Given this list of marker genes Pim1, Pxdc1, Pdlim3, App, Nxn, Laptm4a, Mcl1, Vasn, Calm2, Tubb2a, Zfand5, Sbno2, Adgra3, Icam1, Pdlim7, Ccl7, Emc10, Stac2, Mmp2, Zfp36, Col9a2, Ski, Klc3, Mknk2, Pfdn5, Fosb, Selenom (NCBI Gene Id 216508), Tln1, Gadd45g, Msn, Socs1, Reep5, Ftl1, Zfp703, Tenm2, Clu, Slc6a6, Ptpn14, Bcl7c, Lamb3, Crem, Uap1, Use1, Ralgds, Plpp3, Jun, Pigp, Anp32a, Sertad1, Col6a1 (NCBI Gene Id 12833), Pink1, Rbpms, Gpx3, Map1b, Tmem59, Sgk1, Klf9, Ly6e, Ddah2, Ppp1r15a, Krt5, Rgs2 (regulator of G-protein signaling 2), Nfil3 (NCBI Gene Id 18030), Urah, Btg2, Gstm1, Nr4a1 (NCBI Gene Id 15370), Trim29, Eif3f, Dusp14, Zfp36l1, Il11ra1, Apoe, Rnf19b, Lmod1, Fgg, Gas1, Arid5b (AT-rich interaction domain 5B), Slpi, Emp1 (NCBI Gene Id 13730), Ltbp4, Fgfr1, Rpl13a, Nrtn, Ecrg4, Gnb1, Ctsl, Fhod3, Prelp, Mia, Hspa1a, Scn7a, Bcl3, Tob2, Samd4b, H2-K1, Cldn4, Selenop, Junb, Map1lc3a, Tppp3, Ier5, Itm2c, Rnf122, Camk2n1, Rassf1, Timp3, Fcgrt, Cirbp, Cox7a2l, H2-Ab1, Fxyd6, Ripk1, Dnajb1, Wsb1, Gas6, Pmp22, Gadd45b, Ier2, Fos, Ssbp3, Irf1, Fosl1, Plac9, C1s1, Rgcc, Dkk3 (NCBI Gene Id 97412), Sfn, Pik3r1, Mylk, Bsg, Fryl, Klf4, Errfi1, Cish, Lypd3, Smad7, Skil, Gstt1 (NCBI Gene Id 14871), Timp2, Bambi, Cebpd, Ccl2, Atf3, Gfra2, Asph, Sf3b2, Txnrd1, Gcnt2, Csrnp1, Eef2, Creb5, Ak1, Dcn, Krt14, Grn, Igfbp6, Rflnb, Lmna, Brd2, Bdnf, Tiparp, Lrp1, Jmjd1c, Serping1, Bcam, Rpl3, Plat, Arhgdia, Mtss1, Socs3, Gsn, Krt18, Trf, Tob1, Maff, Slc29a1, Pnrc1, Cavin2, Sfrp1, Btg1 (BTG anti-proliferation factor 1), Ptov1, Klf13, Myd88, Aldh2, Vamp8, Ccnl1, Nfic, Hmgb2, Ptx3, Kitl, Vegfa, Ddx5, Rabac1 (Rab acceptor 1 (prenylated)), Klf2, Klf16, H2az2, Gem, Fam110a, Pcf11, Eya2 (NCBI Gene Id 98933), Csrp1, Boc, Nfix, Thbs1, Hspa2, H3f3b, Hs3st1, Vim, Dnaja1, Smarca2, Kdm6b, Tmem254, Spr, Erf, Plscr1, Hbegf, Echdc2, Aebp1, Bgn, Plekhb1, Sphk1, Tnfrsf1a, Ier3, Clic4, Cst3, Tspan8, Nr4a2, Pde4b, C2cd4b, Tspo, Cebpb, Myl9, Ifitm2, Trib1, Tmem160, Marcksl1, Ly6d, Ly6a, Ubb, Fbln7, Mafk, Cp, Bag3, Tsc22d1, Ptms, Pbxip1, Mbnl1, Rcan1, H2-D1, Midn, Cyb5r3, Psap, Adamts1, Cdkn1a, Crlf2, Cd200, Atp1a1, Tle5, Egr1, Dst, Foxo1, Chka, Fkbp8, Fosl2, Coq10b, F11r, Cxcl12, Slc41a1, Cfl1, Arid5a, Jund, Hspa8, Pim3, Cxcl14, Tmbim6, Itm2b, Rhoc, Dusp1, Pltp, Cnn1, Arc, Cavin3, Tmem50a, Tgif2, Plaat3, Lgals9, Tgfbr1, Zfp36l2, Tm4sf1, Ltbp3, Gnai2, H2-T23, Mdfi, C4b, Sik1, Id3, Bhlhe40, Tmem88b, Il17b, Phlda1, Mgst1, Klf5, Gcc1, Fus, Tmem45a (transmembrane protein 45a), here is a description of the gene set: studied in species Mus musculus from publication Tabula Muris Consortium (PMID 32669714) Mouse Gene Set: TABULA_MURIS_SENIS_MAMMARY_GLAND_BASAL_CELL_AGEING